Given this list of marker genes FOXJ1, CD3E, LYN, ICOS (inducible T cell costimulator), LGALS9, HLA-G, HLA-B, CBLB, ITCH, LILRB2, ACOD1, PSG9, PHLPP1, IRAK3, TNFAIP3, PDCD1, TGFBR2, NR5A2, MARCHF7, CLC, HMGB1, XKR8, CCR4, TGFB1, IDO1 (indoleamine 2,3-dioxygenase 1), IL2RA, HLA-E, FOXP3, LILRB4, AIRE, HAVCR2, here is a description of the gene set: A process that directly activates any of the steps required for tolerance, a physiologic state in which the immune system does not react destructively against the components of an organism that harbors it or against antigens that are introduced to it. species: Homo sapiens Human Gene Set: GOBP_TOLERANCE_INDUCTION